The following is a description of a gene set: part of: RHO GTPase cycle Reactome Pathway: RAC1 GTPase cycle studied in species Homo sapiens This pathway catalogues RAC1 guanine nucleotide exchange factors (GEFs), GTPase activator proteins (GAPs), GDP dissociation inhibitors (GDIs) and RAC1 effectors. RAC1 is one of the three best characterized RHO GTPases, the other two being RHOA and CDC42. RAC1 regulates the cytoskeleton and the production of reactive oxygen species (ROS) and is involved in cell adhesion and cell migration. RAC1 is involved in neuronal development (de Curtis et al. 2014). In neurons, RAC1 activity is regulated by synaptic activation and RAC1-mediated changes in actin cytoskeleton are implicated in dendritic spine morphogenesis, which plays a role in memory formation and learning. RAC1 is involved in metabolic regulation of pancreatic islet β-cells and in diabetes pathophysiology. RAC1-mediated activation of NOX2 contributes to mitochondrial damage and the development of retinopathy in patients with diabetes. RAC1 is important for exercise and contraction-stimulated glucose uptake in skeletal muscles. RAC1 plays an important role in the maintenance of intestinal barrier integrity under physiological conditions and during tissue repair after resolution of colitis. Toxins of many diarrhea-causing bacteria target RAC1. RAC1 is important for skin homeostasis and wound healing and is involved in the pathogenesis of psoriasis. RAC1 is essential to vascular homeostasis and chronically elevated RAC1 signaling contributes to vascular pathology. RAC1 hyperactivation, mutation and copy-number gain are frequently observed in solid tumors., and this is the list of marker genes: PLEKHG3, KALRN, CHN1, PIK3R1, ARHGAP32, ARHGEF6, TAOK3, NCF1, SNAP23, MCAM, ARHGDIB, PREX2, CHN2, ARHGAP10, ECT2, SRGAP2, ARHGAP24, GARRE1, ARHGAP1, TIAM1, PIK3R2, DOCK7, WASF3, ARHGAP23, MYO9B, LAMTOR1, ARHGAP39, ARAP1, PKN2, ARHGAP44, SPATA13, ARHGEF10, BCR, PAK1, VAV1, WAS, ITGB1, CDC42EP4, SOS1, MCF2, PLEKHG4, EMD, SRGAP3, WASF2, SRGAP1, DIAPH3, TFRC, VAV2, ARHGEF19, GNA13, DOCK6, NGEF, ARHGAP26 (NCBI Gene Id 23092), MCF2L, ABI2, BAIAP2, VAMP3, ARHGDIA, FMNL1, ARHGAP33, DOCK4, PLEKHG1, PKN1, CAV1, ARHGAP42, NOX1, WIPF1, NHS, ABI1 (abl interactor 1), FAM13B, DOCK3, SWAP70, CYFIP1, NOXA1, DLC1, ARHGAP45 (NCBI Gene Id 23526), DOCK1, TMPO, CYFIP2 (cytoplasmic FMR1 interacting protein 2), ARHGAP17, WASF1 (WASP family member 1), DOCK9, PIK3CA, ARHGAP25, NOXO1, PLEKHG6, PLEKHG2, PLD1, ABR, YKT6, ARHGAP9, ARHGAP31, NOX3, ARAP3, RAB7A, ARHGAP22, ARHGAP21, NISCH, FERMT2, ARHGAP4, FGD5, RAC1, PLD2, LEMD3, ARAP2, PAK4, BAIAP2L1, CYBB, KTN1, OPHN1, MPP7, DOCK5, RALBP1, CYBA, ARHGAP30, SYDE2, NCKAP1, PAK6, WIPF3, WIPF2, IQGAP2, ARHGAP15, SOS2, SLC1A5, ARHGAP5, ARHGEF11, GIT1, ARHGEF18, SH3BP1, ERBIN (NCBI Gene Id 55914), VRK2, VAV3, LBR, PAK5, TAGAP, PARD6A, DEPDC1B, CDC42BPA, TRIO, NCF4, AMIGO2, FAM13A, ALS2, ABL2, DOCK10, NCKAP1L, NCF2, IQGAP1, FARP1, ARHGEF15, DOCK8, ARHGEF5, JAG1, RACGAP1, ARHGAP27, CDC42, ARHGEF25, GIT2, GMIP, ARHGEF4, ARHGAP20, VANGL1 (VANGL planar cell polarity protein 1), IQGAP3, DOCK2, CDC42EP1, ARHGAP12, DEF6, RASGRF2 (Ras protein specific guanine nucleotide releasing factor 2), TIAM2, PAK3, BRK1, ARHGAP29, ARHGEF7, FARP2, ESYT1, WASL, PREX1, ARHGEF39, PIK3R3, EPHA2, ARHGAP35, PAK2, DOCK11, CIT